The following is a description of a gene set: Human Gene Set: GSE3982_DC_VS_BASOPHIL_DN from publication Jeffrey KL, Brummer T, Rolph MS, Liu SM, Callejas NA, Grumont RJ, Gillieron C, Mackay F, Grey S, Camps M, Rommel C, Gerondakis SD, Mackay CR (PMID 16474395) studied in species Homo sapiens Genes down-regulated in comparison of dendritic cells (DC) versus basophils. In the present study we used Affymetrix oligonucleotide microarrays to produce gene transcription profiles for the major leukocyte types in humans. This comprehensive dataset enabled us to not only establish which genes were expressed in each leukocyte type, but also which genes were expressed in each subset after activation. The used of a comprehensive dataset of gene profiles from all the major human leukocyte subsets enabled a novel and powerful means for identification of genes associated with single leukocyte subsets, or different immune paradigms., and this is the list of marker genes: TPR, PASK, PSME4, RNASE2, ZEB1, ERC2, CEP131, H3C2, ADIRF, IFITM2, SFXN1, CYSLTR1, ZNF665, MALT1, TMSB15B, TRAPPC2, ISG20, SF3A1, MFAP2, TMEM164, SUPT20H, PRMT2, PAPOLG, ANKRD55, TPT1, PMAIP1 (NCBI Gene Id 9305), PCYOX1L, AKR1C2, BCL7B, TAL1 (NCBI Gene Id 6886), SPTLC2, IFITM1 (interferon induced transmembrane protein 1), NUCB2, NLGN3, CSAD, KIF21B, JARID2, CHPT1, NLK, ZNF586, KLF3 (KLF transcription factor 3), MANBA, REPS2, S1PR1, ZNF142, ZMYND8, FAM193A, CNOT8, BTK (Bruton tyrosine kinase), ITGA4, KIF5A, PIP5K1B, ETS2, IGFBP3, C22orf46P, SRSF6, PTMA, MED13L, H4C11, ZXDC, GIT2, UBR7, WASF2, DENND3, NECAP1, ZDHHC13 (NCBI Gene Id 54503), FLT3LG, RHOH, MAGEF1, RPL6, RBM14, LAT2, BCL2L10, ALKBH4, CTDSP2, STK38, PEX1, NAMPT, RPL37, SHCBP1L, TERF2IP, ARHGEF6, MYD88, RNF144A, EIF4EBP2, STAP1, BRD7, KANSL1L, MYB, SIAH2, APOBEC3G, DNAH6, H3-3B, PTP4A1, MTERF1, CARD8, PTGDR2, AKAP17A, BEGAIN, SYNE1, SELPLG, KBTBD2, MEIS2, SMYD3, UBE2D2, LINC00667, HSPA1L, BASP1, CCNL1, RPL34 (ribosomal protein L34), DPP4, RIOK3, PPP2R5A, RPL36, SPOP, BRAP, TRAPPC14, CHN1, MYRIP, CEP63, PAFAH1B3, ERCC5, SLC10A3, ARHGAP15, MAMLD1, GLT8D1 (glycosyltransferase 8 domain containing 1), FBLN5, DSG1, PHF1, PRPF3, GSK3B, OSGIN2, C11orf21, TTC21B, ZNF266, ADGRE2, RLF, SERPIND1, ASMTL, WIPI1, P2RY10, PITPNC1, DPF2, BRD8, OR2F1, SRSF4, TM4SF1, DIDO1, THYN1, CTCF, TRA2A (NCBI Gene Id 29896), HCP5, FAM124B, PRSS2, ZWILCH, HEXIM1, PDE4D, FRMPD1, IL18R1, GRPR, C1RL, RAF1, CXCR4, S100P, TMOD1, INTS12, BACH2 (NCBI Gene Id 653980), TRIM52, SLC25A36, KBTBD11, ZNF394, EIF1, ZDHHC3, ZNF358, WSCD1, FAM8A1, DDIT3, SMARCC2, RHOA, C2orf68, KDM5A, R3HDM2, GALNT3, GVINP1, SORD, AKR1C3, CAMLG, EXT1, MPHOSPH9, CAPRIN2, PPM1H, ABLIM1, MIA3, S100PBP, BTN3A3, MAP1LC3B, OSBPL3, CYLD, CALCOCO2